The following is a description of a gene set: Any process that modulates the rate, frequency or extent of branching involved in ureteric bud morphogenesis, the process in which the branching structure of the ureteric bud is generated and organized. The ureteric bud is an epithelial tube that grows out from the metanephric duct. The bud elongates and branches to give rise to the ureter and kidney collecting tubules. species: Homo sapiens Human Gene Set: GOBP_REGULATION_OF_BRANCHING_INVOLVED_IN_URETERIC_BUD_MORPHOGENESIS, and this is the list of marker genes: LHX1, SIX2, LGR4, PAX8, SMO, BMP4, VEGFA, TGFB1, SIX1, WNT2B, SOX8, NOG, AGT, AGTR2, GDNF, HOXB7, SOX9, MAGED1, TACSTD2, GREM1, SIX4 (NCBI Gene Id 51804)